The following is a description of a gene set: species: Homo sapiens Top 50 down-regulated genes in cluster CD-1 of multiple myeloma samples with the characteristic expression spike of CCND1. from publication Zhan F, Huang Y, Colla S, Stewart JP, Hanamura I, Gupta S, Epstein J, Yaccoby S, Sawyer J, Burington B, Anaissie E, Hollmig K, Pineda-Roman M, Tricot G, van Rhee F, Walker R, Zangari M, Crowley J, Barlogie B, Shaughnessy JD Jr (PMID 16728703) Human Gene Set: ZHAN_MULTIPLE_MYELOMA_CD1_DN To better define the molecular basis of multiple myeloma (MM), we performed unsupervised hierarchic clustering of mRNA expression profiles in CD138-enriched plasma cells from 414 newly diagnosed patients who went on to receive high-dose therapy and tandem stem cell transplants. Seven disease subtypes were validated that were strongly influenced by known genetic lesions, such as c-MAF- and MAFB-, CCND1- and CCND3-, and MMSET-activating translocations and hyperdiploidy. Indicative of the deregulation of common pathways by gene orthologs, common gene signatures were observed in cases with c-MAF and MAFB activation and CCND1 and CCND3 activation, the latter consisting of 2 subgroups, one characterized by expression of the early B-cell markers CD20 and PAX5. A low incidence of focal bone disease distinguished one and increased expression of proliferation-associated genes of another novel subgroup. Comprising varying fractions of each of the other 6 subgroups, the proliferation subgroup dominated at relapse, suggesting that this signature is linked to disease progression. Proliferation and MMSET-spike groups were characterized by significant overexpression of genes mapping to chromosome 1q, and both exhibited a poor prognosis relative to the other groups. A subset of cases with a predominating myeloid gene expression signature, excluded from the profiling analyses, had more favorable baseline characteristics and superior prognosis to those lacking this signature., and this is the list of marker genes: CMTM4, TNS3, TRAM2 (NCBI Gene Id 9697), FUT8, GRAMD2B (GRAM domain containing 2B), ECHDC2, LAX1, BHLHE41, UCP2, DOK3, STARD5, ADAM19, SLCO5A1-AS1, SCAMP5, SLFN11, C1orf115 (chromosome 1 open reading frame 115), GATM, CCDC125, LINC00582, ATP6AP1, HES1, RAB3B, PRKCD, UNC93B1, RAB3IP, UGCG, CD59, FLI1, SLCO5A1, NOTCH2, KIAA0040, SPINT1, SMURF1, ABHD6, F11R, PRKD3, CXXC5, CPEB4, SIK1, BCL2L1, ITPR3, ST6GAL1, CLIC2, CD46, CPNE5, MINDY2, CNTN4